Given this list of marker genes Tradd, Fasl, Fadd, Fas, Casp8, here is a description of the gene set: studied in species Mus musculus Reactome Pathway: CASP8 activity is inhibited This event has been computationally inferred from an event that has been demonstrated in another species.<p>The inference is based on the homology mapping from PANTHER. Briefly, reactions for which all involved PhysicalEntities (in input, output and catalyst) have a mapped orthologue/paralogue (for complexes at least 75% of components must have a mapping) are inferred to the other species. part of: Regulation of necroptotic cell death electronically inferred by orthology from the curated human pathway